The following is a description of a gene set: The directed movement of water (H2O) from one side of an epithelium to the other. species: Homo sapiens Human Gene Set: GOBP_TRANSEPITHELIAL_WATER_TRANSPORT, and this is the list of marker genes: SLC5A1, PKP1, CFTR, AQP8 (aquaporin 8), AQP1